The following is a description of a gene set: Genes up-regulated in granulocytes by RUNX1-RUNX1T1 fusion. from publication Tonks A, Pearn L, Musson M, Gilkes A, Mills KI, Burnett AK, Darley RL (PMID 17898786) Human Gene Set: TONKS_TARGETS_OF_RUNX1_RUNX1T1_FUSION_GRANULOCYTE_UP The t(8;21)(q22;q22) occurs frequently in acute myelogenous leukaemia and gives rise to the transcription factor fusion protein, RUNX1-RUNX1T1 (also known as AML1-ETO). To identify the genes dysregulated by the aberrant transcriptional activity of RUNX1-RUNX1T1, we used microarrays to determine the effect of this mutation on gene expression in human progenitor cells and during subsequent development. Gene signatures of these developmental subsets were very dissimilar indicating that effects of RUNX1-RUNX1T1 are highly context dependent. We focused on gene changes associated with the granulocytic lineage and identified a clinically relevant subset of these by comparison with 235 leukaemia patient transcriptional signatures. We confirmed the overexpression of a number of significant genes (Sox4, IL-17BR, CD200 and gamma-catenin). Further, we show that overexpression of CD200 and gamma-catenin is also associated with the inv(16) abnormality which like RUNX1-RUNX1T1 disrupts core binding factor activity. We investigated the functional significance of CD200 and gamma-catenin overexpression in normal human progenitor cells. The effect of IL17 on growth was also assessed. Individually, none of these changes were sufficient to recapitulate the effects of RUNX1-RUNX1T1 on normal development. These data provide the most comprehensive and pertinent assessment of the effect of RUNX1-RUNX1T1 on gene expression and demonstrate the highly context-dependent effects of this fusion gene. studied in species Homo sapiens, and this is the list of marker genes: DDX39B, CD200 (NCBI Gene Id 4345), LY6E, JUP, MARCHF6, NPR3 (natriuretic peptide receptor 3), GUCY1A1, JAM3, ISYNA1, TAL1, TMEM176B, CRHBP, MACF1, MEF2C, GK, MEIS1, IFI16, KANK2, SOCS2, ALDH1A1, NEFH, FHL1, CDK17, SOX4, TM4SF1, HSPE1, TIE1, CYP1A1, KLHL26, FSCN1 (NCBI Gene Id 6624), IL17RB, TERT (NCBI Gene Id 7015), MTSS1, MYRF, ANGPT1, MECOM, TMEM176A, F2R, RXYLT1, HSPB1, ID1, BCAT1, DNAAF2, ARID5B, ALDH5A1, CDK6, MPL, TAF9B, TFAM, ROBO1, F2RL1, NUDT11, GNAI1, SNN